The following is a description of a gene set: Genes down-regulated in comparison of monocytes from influenza vaccinee pre-vaccination versus those at day 7 post-vaccination. species: Homo sapiens Systems vaccinology has emerged as an interdisciplinary field that combines systems wide measurements and network and predictive modeling applied to vaccinology. Here we used the systems vaccinology approach to study the molecular mechanisms underlying th from publication Nakaya HI, Wrammert J, Lee EK, Racioppi L, Marie-Kunze S, Haining WN, Means AR, Kasturi SP, Khan N, Li GM, McCausland M, Kanchan V, Kokko KE, Li S, Elbein R, Mehta AK, Aderem A, Subbarao K, Ahmed R, Pulendran B (PMID 21743478) Human Gene Set: GSE29618_PRE_VS_DAY7_FLU_VACCINE_MONOCYTE_DN, and this is the list of marker genes: MTR, GSR, SRSF1 (serine and arginine rich splicing factor 1), ZFP64, S100PBP, ZFAND5, MED20, EGR1, MMACHC, ZNF225, CENPE, CPNE1, IER5, KLRC4, GFM1, DCTN2, ANAPC5 (anaphase promoting complex subunit 5), CA7, AAR2 (AAR2 splicing factor), STRN4, TJAP1, TRIM15, CHERP, CCL4, GUSBP11, PTCD1, MPL, HSPA1A, MEIS1, EXOSC10, ZNF222, IER2, UQCRFS1, KLHL41, TMC5, COCH, EIF4E2, GPATCH1, SLC30A1, SYNPO, DPP8, SCYL3, PDE6C, OSBPL8, CLDN17, DSTNP2, MRPL23, TNFRSF10C, NDUFAF7, PPP1R10, MEGF8, ZNF189, FANCI, PHC2, CCNL1, STAM2, RBBP4, LSM1, CNGA3, GCN1, REV1, PSMD14, GLS2, MED27, COMMD3, TAF1C, UNC119B, ZNF84, ASXL1, GATB, TNFAIP1, YIPF2, SYNRG (NCBI Gene Id 11276), METTL5, EIF4G3, TNF, ARHGAP10 (NCBI Gene Id 79658), SORD, AKR1C2 (aldo-keto reductase family 1 member C2), ZBBX, TDP2, CRNKL1, XPO1, ZNF146, ZNF85, ZBTB10, CALCR, CAB39, SRSF7, OSR2, SMC5 (NCBI Gene Id 23137), SCRIB, ELOVL4, TRIM37, NCKIPSD, CLCN7, PRMT2, CDC25B, PROSER1, ARHGAP25, MMS19, ARF4, SIGLEC9, CHST3, KPNA2, RAB3GAP2, PIGP, NDUFB1, RANBP10, DEXI (NCBI Gene Id 28955), NAALAD2, UBE2V2, PPP2R5E, BTG2, RPGRIP1, WFDC8, SEC24D, CSF2RA, SLC6A20, PPOX, APAF1, PER2, CD180, ASF1A, XYLB, SPP2, KLF6, TRA2B, TADA2A, JADE1, USE1, ZNF254, PCNX1, UBR4, MBL1P, PDLIM5, FAM216A, RPL36AL, MID1IP1, RSRP1, CERS2 (ceramide synthase 2), ATP13A1, RAB13 (RAB13, member RAS oncogene family), WDR6, ARHGAP19, MEN1, MRPL17, ADRA2A, CYP11B1, ALKBH1, PAPPA2, CD3D, DDHD2, KANK3, TUBA4A, ZDHHC17, DYNC2I1, LMO3, TMEM184C, GALNT2, PRAMEF10, ACP6, OGFOD3, CLEC2D, NOP14-AS1, RPAP1, IL27RA, DUOX1, TTF2, PTGDR, EEF2KMT, DPY19L4, REPS2, IARS1, DCAF4, CNOT1, PSMD3, ATP6V1C1, TRDV2, MYC, NENF, MELK, WWP2, SDHAF1, TAOK2, FIRRM, ABHD10, IFFO1, IP6K1, UBR2, ACSS3, CCAR2, HEMK1, TPPP, ARAP3, CLDN18, ZNF432, CD163, KCNK1